Given this list of marker genes DGKH, TRPC6, ITPR2, DGKQ, PRKCH, DGKE, ITPR1, RASGRP2, DGKI, DGKA, ABHD6, ITPR3, DGKB, TRPC7, DAGLA, ABHD12, PRKCD, DGKZ, PRKCE, TRPC3, DGKD, DGKG, PRKCQ, DAGLB, MGLL, RASGRP1, DGKK, here is a description of the gene set: Human Gene Set: REACTOME_EFFECTS_OF_PIP2_HYDROLYSIS studied in species Homo sapiens Effects of PIP2 hydrolysis